Given this list of marker genes Stk39, Wnk4, Nr1h3, Wnk3, Wnk1 (NCBI Gene Id 406236), here is a description of the gene set: Any process that decreases the rate, frequency or extent of pancreatic juice secretion, the regulated release of pancreatic juice by the exocrine pancreas into the upper part of the intestine. Mouse Gene Set: GOBP_NEGATIVE_REGULATION_OF_PANCREATIC_JUICE_SECRETION studied in species Mus musculus